Given this list of marker genes Cpeb3, Rpl13a, Eif2ak4, Lin28a, Cpeb4, Unk, Cpeb2 (NCBI Gene Id 277866), Cnbp, Akt2, Hnrnpd, Sh3bgrl, Alkbh3, Igf2bp1, Nmnat2, Paip1, Syncrip, Zfp385a, Piwil1, Mettl3, Pkp1, Pabpc1, Ythdf2, Zcchc13, Cpeb1, Rbm24, Pkm, Ybx1, Fmr1, Csde1, Dhx36, Piwil2, Impact, Parp16, Eef2, Nck1, Hnrnpu, Dhx9, here is a description of the gene set: Mouse Gene Set: GOBP_REGULATION_OF_CYTOPLASMIC_TRANSLATION Any process that modulates the frequency, rate or extent of cytoplasmic translation. studied in species Mus musculus